Given this list of marker genes PLOD1, LAMC2, MMP3, COL18A1, COL2A1, COL14A1, LOXL3, CTSV, COL3A1, COL4A3, COL6A1, CD151, COL6A5, COL4A4, PLOD2, SERPINH1, COL28A1, COL9A2, COL27A1, LOXL2, ITGB4, P3H1, COL13A1, MMP20, LOX, PXDN, DST, COL23A1, LAMB3, P4HB, ADAMTS2, LAMA3, PCOLCE2, COL26A1, P4HA1, ITGA6, P3H3, COL4A5 (NCBI Gene Id 1287), P4HA2, COL17A1, COL4A2, TLL2, COL9A3, PCOLCE, P4HA3, CTSS, COL15A1 (NCBI Gene Id 1306), COL8A2, BMP1, COL22A1, COL24A1, CTSL, PLEC, COL9A1, COL1A2, COL12A1, COL20A1, COL5A1, COL19A1, COL11A1, CRTAP, P3H2, COL21A1, TLL1, COL8A1, CTSB, MMP13, COL6A2, COL25A1, PPIB, COL7A1, COLGALT2, LOXL1, COL5A3, COL6A6, COL1A1, PLOD3, COLGALT1, COL6A3, COL11A2, MMP7, ADAMTS3, COL4A6, COL5A2, MMP9, COL4A1, ADAMTS14, LOXL4, COL16A1, COL10A1, here is a description of the gene set: Reactome Pathway: Collagen formation studied in species Homo sapiens Collagen is a family of at least 29 structural proteins derived from over 40 human genes (Myllyharju & Kivirikko 2004). It is the main component of connective tissue, and the most abundant protein in mammals making up about 25% to 35% of whole-body protein content. A defining feature of collagens is the formation of trimeric left-handed polyproline II-type helical collagenous regions. The packing within these regions is made possible by the presence of the smallest amino acid, glycine, at every third residue, resulting in a repeating motif Gly-X-Y where X is often proline (Pro) and Y often 4-hydroxyproline (4Hyp). Gly-Pro-Hyp is the most common triplet in collagen. Collagen peptide chains also have non-collagenous domains, with collagen subclasses having common chain structures. Collagen fibrils are mostly found in fibrous tissues such as tendon, ligament and skin. Other forms of collagen are abundant in cornea, cartilage, bone, blood vessels, the gut, and intervertebral disc. In muscle tissue, collagen is a major component of the endomysium, constituting up to 6% of muscle mass. Gelatin, used in food and industry, is collagen that has been irreversibly hydrolyzed. On the basis of their fibre architecture in tissues, the genetically distinct collagens have been divided into subgroups. Group 1 collagens have uninterrupted triple-helical domains of about 300 nm, forming large extracellular fibrils. They are referred to as the fibril-forming collagens, consisting of collagens types I, II, III, V, XI, XXIV and XXVII. Group 2 collagens are types IV and VII, which have extended triple helices (>350 nm) with imperfections in the Gly-X-Y repeat sequences. Group 3 are the short-chain collagens. These have two subgroups. Group 3A have continuous triple-helical domains (type VI, VIII and X). Group 3B have interrupted triple-helical domains, referred to as the fibril-associated collagens with interrupted triple helices (FACIT collagens, Shaw & Olsen 1991). FACITs include collagen IX, XII, XIV, XVI, XIX, XX, XXI, XXII and XXVI plus the transmembrane collagens (XIII, XVII, XXIII and XXV) and the multiple triple helix domains and interruptions (Multiplexin) collagens XV and XVIII (Myllyharju & Kivirikko 2004). The non-collagenous domains of collagens have regulatory functions; several are biologically active when cleaved from the main peptide chain. Fibrillar collagen peptides all have a large triple helical domain (COL1) bordered by N and C terminal extensions, called the N- and C-propeptides, which are cleaved prior to formation of the collagen fibril. The intact form is referred to as a collagen propeptide, not procollagen, which is used to refer to the trimeric triple-helical precursor of collagen before the propeptides are removed. The C-propeptide, also called the NC1 domain, directs chain association during assembly of the procollagen molecule from its three constituent alpha chains.<br><br>Fibril forming collagens are the most familiar and best studied subgroup. Collagen fibres are aggregates or bundles of collagen fibrils, which are themselves polymers of tropocollagen complexes, each consisting of three polypeptide chains known as alpha chains. Tropocollagens are considered the subunit of larger collagen structures. They are approximately 300 nm long and 1.5 nm in diameter, with a left-handed triple-helical structure, which becomes twisted into a right-handed coiled-coil 'super helix' in the collagen fibril. Tropocollagens in the extracellular space polymerize spontaneously with regularly staggered ends. In fibrillar collagens the molecules are staggered by about 67 nm, a unit known as D that changes depending upon the hydration state. Each D-period contains slightly more than four collagen molecules so that every D-period repeat of the microfibril has a region containing five molecules in cross-section, called the 'overlap', and a region containing only four molecules, called the 'gap'. The triple-helices are arranged in a hexagonal or quasi-hexagonal array in cross-section, in both the gap and overlap regions. Collagen molecules cross-link covalently to each other via lysine and hydroxylysine side chains. These cross-links are unusual, occuring only in collagen and elastin, a related protein.<br><br>The macromolecular structures of collagen are diverse. Several group 3 collagens associate with larger collagen fibers, serving as molecular bridges which stabilize the organization of the extracellular matrix. Type IV collagen is arranged in an interlacing network within the dermal-epidermal junction and vascular basement membranes. Type VI collagen forms distinct microfibrils called beaded filaments. Type VII collagen forms anchoring fibrils. Type VIII and X collagens form hexagonal networks. Type XVII collagen is a component of hemidesmosomes where it is complexed wtih alpha6Beta4 integrin, plectin, and laminin-332 (de Pereda et al. 2009). Type XXIX collagen has been recently reported to be a putative epidermal collagen with highest expression in suprabasal layers. Collagen fibrils/aggregates arranged in varying combinations and concentrations in different tissues provide specific tissue properties. In bone, collagen triple helices lie in a parallel, staggered array with 40 nm gaps between the ends of the tropocollagen subunits, which probably serve as nucleation sites for the deposition of crystals of the mineral component, hydroxyapatite (Ca10(PO4)6(OH)2) with some phosphate. Collagen structure affects cell-cell and cell-matrix communication, tissue construction in growth and repair, and is changed in development and disease. A single collagen fibril can be heterogeneous along its axis, with significantly different mechanical properties in the gap and overlap regions, correlating with the different molecular organizations in these regions (Minary-Jolandan & Yu 2009). part of: Extracellular matrix organization